The following is a description of a gene set: species: Mus musculus Mouse Gene Set: GOCC_ENDOLYSOSOME An transient hybrid organelle formed by fusion of a late endosome with a lysosome, and in which active degradation takes place., and this is the list of marker genes: Abcb6, Tasl, Clec16a, Rnf167, Slc15a4, Tpcn2 (NCBI Gene Id 233979), Prkcd, Tlr9, Atg16l1, Mpeg1, Slc48a1, Smpd1, Tpcn1